Given this list of marker genes SLC17A6, CRY2, SFRP4, SLC34A2, ATF4, SLC17A7, SLC34A3, SLC34A1, CEBPB, SLC17A4, SLC17A8 (solute carrier family 17 member 8), SLC17A1, here is a description of the gene set: species: Homo sapiens The directed movement of phosphate into, out of or within a cell, or between cells, by means of some agent such as a transporter or pore, by a mechanism dependent upon sodium ions. Human Gene Set: GOBP_SODIUM_DEPENDENT_PHOSPHATE_TRANSPORT